The following is a description of a gene set: studied in species Homo sapiens Any process that modulates the frequency, rate or extent of secondary metabolism, the chemical reactions and pathways involving compounds that are not necessarily required for growth and maintenance of cells, and are often unique to a taxon. Human Gene Set: GOBP_REGULATION_OF_SECONDARY_METABOLIC_PROCESS, and this is the list of marker genes: ATP7A, MFSD12, ZEB2, SLC24A5, RAPGEF2, GIPC1, CDH3, APPL1, SLC7A11, CTNS, WNT5A, PMEL, TYRP1, RAB38, ASIP, OPN3